Given this list of marker genes STAT4, HSD11B1, RRP1B, MFSD6, RARG, FLVCR2, ITGB7, GALNT10, VPS26B, B3GALT4, ITPKB, DNAJC15, CCDC102A, IRF6, PPM1J, ENO1, GSR, IFITM10, BDH1, ACAA2, ERAP1, XRN2, SRSF12, LRRC75B, ITGB2, QSOX1, SLC11A2, RORA (NCBI Gene Id 6095), GPR146, FAM241A, ACSBG1, ZDHHC15, MACROD1, JAK1, BICDL1 (NCBI Gene Id 92558), SYTL2, SLA2, SLC2A9, PRKAG1, TNIK, FOCAD, PPT2, DENND4C, SMPDL3A, TGFA, CLN3, TESC, EOMES, PXYLP1, AMPD1, SKAP1, GARIN3, ADGRG5, SRPK1, PADI2, NCKAP5L, EML5 (EMAP like 5), BACE1, AFP, CLN6, FGF13, CEP97, RNASEL, HDHD5 (NCBI Gene Id 55649), ARHGAP1, RGS3, SMURF1, SIT1, SERPINB9, GRAMD4, IL6ST, KCNC3, TIMELESS, SMPD5, MBNL1, CNN2, LIME1, XDH, KBTBD11, EID2, PIP5KL1, SSBP2, CCR9, KCNMB4, LPCAT4, CCS, BTBD6, SPICE1, PTGER2, SNHG7, SLC9A9, RUNDC3B, THADA, CDKN1A, TMEM120B, SLC20A1, DDX60, PSME2, HDAC4, SYT12, SCP2, DCUN1D3, SNHG17, ATP8B4, IFIT1, PDCD6IP, IL6R, CCND3, ADGRL1, STXBP5, CRIM1 (cysteine rich transmembrane BMP regulator 1), ESYT2, ZC3HAV1L, LGALS3BP, CACNA2D4, SLC5A3, TMLHE, GOSR1, RAB37, RINL, ARL4D, NT5E, MBP, MYL6, LBP, ZNF623, EPHB6, ORAI2, PDHA1, KIF2A, IL18RAP, SMC4, DLG4, LASP1, PPP2R5A, RRP9, ZAP70, PRKACB, FNTB, SBSN, ADGRG3, STK38, RAB8B, LPIN1, DGKA, SLCO3A1, SFMBT2, ISOC1, CAMKK1, PIWIL4, GALNT7 (NCBI Gene Id 51809), FRMD4A, P2RX7, ANGPTL4 (angiopoietin like 4), IGFLR1, PCED1B, TUBB, NBEAL2, ABHD8, METTL9, FAM234A, TBXA2R, HCST, PREX1, SLC35G1, MYRFL, GPR15, TTLL12, PIK3R5, SEPTIN9, SETD4, EVL, DNAJC1, PELI1, ARL15, DGKZ, PLD3, POLR1B, PSME1, ATP8B2, LDLRAP1, EXTL2, RCN1, ETFBKMT, CYTH3, C19orf12, CD7 (CD7 molecule), CRTAM, ACCS, RNF125, TBC1D2B, CLIP1, TMIE, RAP2B, SPATA13, FRMD8, EVA1B, METTL27, LFNG, BAIAP3, here is a description of the gene set: Histone acetyltransferases (HATs) and deacetylases (HDACs) function antagonistically to control histone acetylation. As acetylation is a histone mark for active transcription, HATs have been associated with active and HDACs with inactive genes. We describe here genome-wide mapping of HATs and HDACs binding on chromatin and ﬁnd that both are found at active genes with acetylated histones. Our data provide evidence that HATs and HDACs are both targeted to transcribed regions of active genes by phosphorylated RNA Pol II. Furthermore, the majority of HDACs in the human genome function to reset chromatin by removing acetylation at active genes. Inactive genes that are primed by MLL-mediated histone H3K4 methylation are subject to a dynamic cycle of acetylation and deacetylation by transient HAT/HDAC binding, preventing Pol II from binding to these genes but poising them for future activation. Silent genes without any H3K4 methylation signal show no evidence of being bound by HDACs. studied in species Homo sapiens from publication Wang Z, Zang C, Cui K, Schones DE, Barski A, Peng W, Zhao K (PMID 19698979) Genes down-regulated in CD4 T cells: control versus treated with HDAC inhibitors for 12h. Human Gene Set: GSE15735_CTRL_VS_HDAC_INHIBITOR_TREATED_CD4_TCELL_12H_DN